Given this list of marker genes OPN1MW, ACO2, OPA3, C1QTNF5, CACNA1F, NR2E3, OPA1, FGF14, NDUFS2, PAX6, OPN1LW, MFSD8, FOXC1, TRIM44, here is a description of the gene set: Red-green dyschromatopsia Human Gene Set: HP_RED_GREEN_DYSCHROMATOPSIA Difficulty with discriminating red and green hues. species: Homo sapiens